The following is a description of a gene set: from publication Chen Y, Wang X (PMID 31504780) species: Homo sapiens Human Gene Set: MIR491_3P Genes predicted to be targets of miRBase v22 microRNA hsa-miR-491-3p in miRDB v6.0 with MirTarget v4 prediction scores > 80 (high confidence targets)., and this is the list of marker genes: ANGPT2, P4HA1, LARP4, CHIC1, FABP7, IL18R1, GPBP1L1, ADD3, CLEC4E, PCGF5, KPNA4, RAPGEF5, EEA1, CABP7, USP12 (NCBI Gene Id 219333), TBC1D19, MTX3, CFAP44, DYNC2I1, SHCBP1, KCNC2 (NCBI Gene Id 3747), GALNT15, ATG4A, LRBA, MUC5AC, CLDN23, HSPA2, BCAT1, MINDY2, COL4A4, MARF1, SLC7A14, FOXO3, GYPA, UBE2D3, GRIA1, DYRK1A, STON2, MGAT2, SBNO1, NEK2, TRIO, PDS5A, SLC12A1, ETFBKMT, DUSP4, JCHAIN, RANBP9, AFG1L, TNN, CNNM4, UQCRB, DUSP19, CEP55, ANKDD1A, PPP3R1, MYNN, THAP5, ZFP37, SLC25A46, LIN9 (NCBI Gene Id 286826), DDX21, RBM46, NOM1, TRIP12, ADAMTS5, PTAR1, KANSL1, PTPRM, CRAMP1, PUM2, SLC5A7, GNPTG, SP3, UXS1, MKX, CD247, ABI1, ERCC8, NOVA1, CHM, DNAAF11 (dynein axonemal assembly factor 11), RAPH1, PHIP, ANKRD30A, IKZF4, AIG1, VTI1A, THBD, AZI2, PRKAR2B, PRICKLE2, KCNB2, OTX2, SLC17A3, AGGF1, MTF1, DCN, PDCL, RICTOR, ZC3H12B, VWC2, DPM1, TP53INP1, TRPC1, ELAVL4, GABPA, PDCD6IP (programmed cell death 6 interacting protein), TGFBR3, SNN, GOPC, PRP4K, SIRT1, RHAG, GABRB2, PCDH7, FOXN2, BNC2, CTSS, PIAS2